Given this list of marker genes Ireb2 (iron responsive element binding protein 2), Aco2, Brip1 (BRCA1 interacting protein C-terminal helicase 1), Ppat, Rtel1, Nfu1, Rsad1, Aco1, Dph2, Dna2, Ndufs1, Dph1, Rev3l (NCBI Gene Id 19714), Nubp2, Nubp1, Ndufs8, Cdk5rap1, Mocs1, Ciapin1, Ercc2, Sdhb, Polr3f, Tyw1, Lias, Mutyh, Abce1, Ddx11, Ndufv1, Mettl17, Cdkal1, Ciao3, Prim2, Ndufs2, Elp3, Exo5, Nthl1, Rsad2, Dpyd, Ndufs7, Isca2, Nubpl, Pold1, Etfdh, Pole, here is a description of the gene set: studied in species Mus musculus Mouse Gene Set: GOMF_4_IRON_4_SULFUR_CLUSTER_BINDING Binding to a 4 iron, 4 sulfur (4Fe-4S) cluster; this cluster consists of four iron atoms, with the inorganic sulfur atoms found between the irons and acting as bridging ligands.